Given this list of marker genes Rps27l, Rps15, Rpl15, Rps19, Rps3a1, Rps11, Rps25, Rpl37, Rpl14, Rpl37rt, Rps8, Ubb, Rpl12, Rpl18a, Rps18, Rpl23a, Magoh, Rps20, Rpl39, Rpl13, Smg8, Rpl9, Rpl18, Rpl3l, Dcp1a, Fau, Smg7 (SMG7 nonsense mediated mRNA decay factor), Rpl38, Rps23, Rps12, Rpl37a, Rpl29, Upf3b, Rpl27, Rpl19, Rnps1, Rps4x, Rpl24, Rps2, Rpl36al, Rps17, Rplp2, Rpl27a, Rps26, Rpl39l, Rps28, Rpl3, Rpl7, Ppp2r2a (NCBI Gene Id 71978), Gspt2, Pabpc1, Rps13, Rps7 (ribosomal protein S7, NCBI Gene Id 20115), Magohb, Rpl4, Casc3, Rps5, Rpl6, Rpl26, Upf2, Rps10 (NCBI Gene Id 67097), Rpl36a, Rps9, Rps24, Rpl11, Rps6, here is a description of the gene set: This event has been computationally inferred from an event that has been demonstrated in another species.<p>The inference is based on the homology mapping from PANTHER. Briefly, reactions for which all involved PhysicalEntities (in input, output and catalyst) have a mapped orthologue/paralogue (for complexes at least 75% of components must have a mapping) are inferred to the other species. electronically inferred by orthology from the curated human pathway Reactome Pathway: Nonsense Mediated Decay (NMD) enhanced by the Exon Junction Complex (EJC) part of: Nonsense-Mediated Decay (NMD) studied in species Mus musculus